The following is a description of a gene set: studied in species Homo sapiens Human Gene Set: GOBP_INSULIN_RECEPTOR_SIGNALING_PATHWAY The series of molecular signals generated as a consequence of the insulin receptor binding to insulin., and this is the list of marker genes: RHOQ, GRB14, DNAI1, MIR15B, GSK3A, PTPN11, MIR195, MSTN, GRB10, CSRP3, ZNF592, FOXO4, C2CD5, MIR107, TRIM72, PDK2, TRIB3, GKAP1, RBX1, RPS6KB1, TNS2, SLC27A4, PIK3CA, IGF2, SNX5, INPP5K, SH2B2, AKT2, SMARCC1, FOXC2, APPL1, SIRT1, PHIP, PIK3R2, SOS2, PTPN1, PTPRJ, MTOR, EIF4EBP2 (NCBI Gene Id 1979), INSRR, SESN3, FFAR3, VWA2, NCK1, SOCS3, BCAR1, SERPINA12, GPLD1, PRKCQ, GRB7, PIK3R1, MAPK3, SIK2, GRB2 (NCBI Gene Id 80715), BLVRB, MTCL2, CUL7, PIP4K2C (phosphatidylinositol-5-phosphate 4-kinase type 2 gamma), FOXO1, PRKCZ, FER, IRS4, RELA, IL1B, APC, BCAR3, RPS6KB2, OSBPL8, RBM4, SORBS1, PTPN2, SLC39A14, NCL, OGT, ERFE (NCBI Gene Id 151176), ZNF106, SOCS7, MAPK1, PIP4K2B, LEP, PTPRE, NAMPT, SREBF1, SOS1, RARRES2, SOCS1, AKT1, SLC2A8, IRS2, PIP4K2A, NCOA5, NUCKS1, NDEL1, PIK3C2A, BAIAP2 (BAR/IMD domain containing adaptor protein 2), PIK3R3, AP3S1, AHSG, GPR21, IGFBP1, ADIPOR1 (NCBI Gene Id 95409), MIR103A1, COL6A1, ZBTB7B, PAK1, IGF1R, GAB1, LONP1, PID1, IGF1, MIR1271, SHC1, STXBP4, ENPP1, SORL1, MZB1, IDE, CAV2, INS, TSC2, MAPKAP1, PRKCD, GSK3B, KANK1, FBXW8, FUT7, PRKCB (protein kinase C beta), NR1H4, RAF1, INSR, PDK4, PRKAA1, C1QTNF12, PDPK1, IRS1, CTSD, HRAS (HRas proto-oncogene, GTPase)